The following is a description of a gene set: An ionotropic glutamate receptor activity that exhibits fast gating by glutamate and acts by opening a cation channel permeable to sodium, potassium, and, in the absence of a GluR2 subunit, calcium. species: Mus musculus Mouse Gene Set: GOMF_AMPA_GLUTAMATE_RECEPTOR_ACTIVITY, and this is the list of marker genes: Gria2, Gria1, Grid1, Grid2, Gria4, Gria3